The following is a description of a gene set: species: Homo sapiens Human Gene Set: REACTOME_WNT5A_DEPENDENT_INTERNALIZATION_OF_FZD2_FZD5_AND_ROR2 WNT5A-dependent internalization of FZD2, FZD5 and ROR2, and this is the list of marker genes: WNT5A, AP2A1, FZD2, ROR2, AP2B1 (NCBI Gene Id 163), AP2S1, AP2A2, FZD5, CLTC (NCBI Gene Id 9511), AP2M1, ROR1, CLTB, CLTA